Given this list of marker genes Shh, Gdf3 (growth differentiation factor 3), Ssbp3, Smad4, Ntf5, Nodal, Pax6, here is a description of the gene set: Mouse Gene Set: GOBP_FORMATION_OF_ANATOMICAL_BOUNDARY species: Mus musculus The process in which the limits of an anatomical structure are generated. An anatomical structure is any biological entity that occupies space and is distinguished from its surroundings. Anatomical structures can be macroscopic such as a carpel, or microscopic such as an acrosome.